Given this list of marker genes BCL11A, EIF2AK3, STRN, PPM1B, FN1, PRKAR1A, EML4, CLTC, BIRC6, ALK (ALK receptor tyrosine kinase), HIP1, NPM1, here is a description of the gene set: part of: Signaling by ALK in cancer species: Homo sapiens Aberrant signaling by activated forms of ALK can be inhibited by tyrosine kinase inhibitors (TKIs). ALK, like other tyrosine kinase receptors, is activated through a series of phosphorylation and conformational changes that move the receptor from the inactive form to the fully activated form. Type II TKIs bind to the inactive form of the receptor at a site adjacent to the ATP-binding cleft, while type I TKIs bind to the active form. Type I inhibitors crizotinib, brigatinib, alectinib, ceritinib and lorlatinib are all approved for treatment of ALK-dependent cancer. Development of resistance to TKIs is not uncommon, however, either through acquisition of secondary mutations or through activation of bypass pathways that remove the dependence on ALK signaling. Reactome Pathway: ALK mutants bind TKIs